The following is a description of a gene set: studied in species Homo sapiens Human Gene Set: GOMF_RNA_7_METHYLGUANOSINE_CAP_BINDING Binding to a 7-methylguanosine group added cotranscriptionally to the 5' end of RNA molecules transcribed by polymerase II., and this is the list of marker genes: DCPS, AGO2, EIF4E1B, CYFIP2, CYFIP1, LARP1 (NCBI Gene Id 91673), EIF4E3, NCBP1, EIF4E, GEMIN5, EIF4E2, NCBP2, NCBP3